The following is a description of a gene set: Increased space between two adjacent teeth in the same dental arch. Human Gene Set: HP_DIASTEMA Diastema studied in species Homo sapiens, and this is the list of marker genes: TUBGCP2, CHSY1, TCF12, ATRX, ARSK, ABCC9, IFT57, UBE3B, NAA80, FREM1, KDM5C, MGAT2, DNMT3A, SMC5, NHS, ACTL6B, KCNMA1, ALX3, PACS1, HRAS, GATAD2B, HMGB3, PRKACA, STAG1, RDH11, RNF2 (NCBI Gene Id 6045), ANKRD11